Given this list of marker genes Tmem106a, Isl1, Ifi209, Hmgb1, Hk1, Gsdma3, Ccl19, Lilra5, Nod2, Il17a, Casp4, Ifi214, Wnt5a, Cd36, Fzd5, Ifi207, Smad3, Ccn1, Egr1, Myd88, Stat3, Tyrobp, Il6, F2rl1, Jak2, Panx1, Naip5, Inava, Lpl, Tlr6, Ifi203, Nlrp1a, Ifnar1, Clec7a, Rela, Ripk2, Ccr7, Mndal, Gsdmd (gasdermin D), Hspb1, Ifi206, Ager, Ifng, Tlr2, Tlr8, Nlrc4, Pycard, Nlrp3, Ccr5, Stmp1, App, Tlr4, Ifi203-ps (interferon activated gene 203, pseudogene), Nod1, Gbp5, Mefv, Usp50, Tnf, Malt1, Ifi213, Aim2, Casp8 (caspase 8), Casp1, Nlrp1b, Ifi208, Ccl3, P2rx7, here is a description of the gene set: studied in species Mus musculus Any process that activates or increases the frequency, rate, or extent of interleukin-1 beta production. Mouse Gene Set: GOBP_POSITIVE_REGULATION_OF_INTERLEUKIN_1_BETA_PRODUCTION